The following is a description of a gene set: studied in species Mus musculus Mouse Gene Set: GOMF_CATECHOLAMINE_BINDING Binding to catecholamine., and this is the list of marker genes: Drd1, Drd4, Gpr143, Slc6a3, Adrb2, Adra2c, Th, Rnls, Adrb3, Adra2b, Drd5, Adra2a, Drd2